Given this list of marker genes KIF11, UBE2C, RRM1, CCNB2, SMC4, DLGAP5, HMMR, NUSAP1, PRC1, CENPE, RRM2, TOP2A, FEN1, CDCA3, CDC20, AURKA, ESPL1, GINS2, KIF20A, BUB1, ASPM, CKS2, FOXM1, TTK, TYMS, MCM2, PLK4, MKI67, BIRC5, PCNA, CCNA2, CENPF, MCM4, NDC80 (NDC80 kinetochore complex component), KIF18B, PLK1, GMNN, AURKB, E2F8, RFC3, ZWINT, CDCA8, SMC2, CDK1, MELK, SHCBP1, BUB1B, here is a description of the gene set: Human Gene Set: GNF2_HMMR species: Homo sapiens Neighborhood of HMMR Neighborhood of HMMR hyaluronan-mediated motility receptor (RHAMM) in the GNF2 expression compendium